The following is a description of a gene set: The chemical reactions and pathways resulting in the breakdown of cysteine, 2-amino-3-mercaptopropanoic acid. studied in species Homo sapiens Human Gene Set: GOBP_CYSTEINE_CATABOLIC_PROCESS, and this is the list of marker genes: CBS, CDO1, CSAD, AGXT, ENSG00000274276